The following is a description of a gene set: Genes up-regulated in ex-vivo colonic tissue after treatment with IL22. species: Mus musculus Infections by attaching and effacing (A/E) bacterial pathogens, such as Escherichia coli O157:H7, pose a serious threat to public health. Using a mouse A/E pathogen, Citrobacter rodentium, we show that interleukin-22 (IL-22) has a crucial role in the early phase of host defense against C. rodentium. Infection of IL-22 knockout mice results in increased intestinal epithelial damage, systemic bacterial burden and mortality. We also find that IL-23 is required for the early induction of IL-22 during C. rodentium infection, and adaptive immunity is not essential for the protective role of IL-22 in this model. Instead, IL-22 is required for the direct induction of the Reg family of antimicrobial proteins, including RegIIIbeta and RegIIIgamma, in colonic epithelial cells. Exogenous mouse or human RegIIIgamma substantially improves survival of IL-22 knockout mice after C. rodentium infection. Together, our data identify a new innate immune function for IL-22 in regulating early defense mechanisms against A/E bacterial pathogens. from publication Zheng Y, Valdez PA, Danilenko DM, Hu Y, Sa SM, Gong Q, Abbas AR, Modrusan Z, Ghilardi N, de Sauvage FJ, Ouyang W (PMID 18264109) Human Gene Set: ZHENG_IL22_SIGNALING_UP, and this is the list of marker genes: TTC9, MS4A6A, CD14, SPINK9, PF4, OLR1, CCL5, IL33, PTX3, S100A9, LILRB1, FREM1, RETNLB, NECTIN4, FZD1, MFSD2A, DMKN, ARG1, CELSR1, TIMP1, CD38, STOM (NCBI Gene Id 2040), THBD, HP, HBB, PFKFB3, SLFN13, INHBA, CCL8, STING1, C3, SLFN12, SLC25A30, CFD, NCMAP, S100A8, HBA2, CXCL6, DSC2, RTN1, CSTA, AMER2 (NCBI Gene Id 219287), ARRDC4, APAF1, TGM1, CFB, CLDN1, PLAT, SLPI, SLITRK1, OXTR, TIFA, SBNO2, TAC1, STXBP5L, ALDH1L1, REG3A, LRG1